Given this list of marker genes SGK1 (serum/glucocorticoid regulated kinase 1), SCNN1G, SCNN1D (NCBI Gene Id 6339), HCN2 (hyperpolarization activated cyclic nucleotide gated potassium and sodium channel 2), SCNN1A, SCNN1B, AIFM1, here is a description of the gene set: Any process that results in a change in state or activity of a cell (in terms of movement, secretion, enzyme production, gene expression, etc.) as a result of an aldosterone stimulus. Human Gene Set: GOBP_CELLULAR_RESPONSE_TO_ALDOSTERONE species: Homo sapiens